The following is a description of a gene set: from publication Chen Y, Wang X (PMID 31504780) Genes predicted to be targets of miRBase v22 microRNA hsa-miR-3615 in miRDB v6.0 with MirTarget v4 prediction scores > 80 (high confidence targets). Human Gene Set: MIR3615 species: Homo sapiens, and this is the list of marker genes: HNMT, KCTD12, NBPF14, MAPRE2, ARRDC2, C14orf119, ACHE, S1PR1, NWD1